The following is a description of a gene set: Human Gene Set: GOBP_REGULATION_OF_CHEMOKINE_MEDIATED_SIGNALING_PATHWAY species: Homo sapiens Any process that modulates the rate, frequency or extent of a chemokine-mediated signaling pathway., and this is the list of marker genes: RNF113A, SH2B3, ROBO1, HIF1A, CCL5, MIR101-1, PADI2, MIR20A, SLIT2, SLIT3, EDN1, TREM2